The following is a description of a gene set: studied in species Homo sapiens Any process that starts or increases the frequency, rate or extent of sister chromatid segregation during mitosis. Human Gene Set: GOBP_POSITIVE_REGULATION_OF_MITOTIC_SISTER_CHROMATID_SEGREGATION, and this is the list of marker genes: MAD1L1, CDK1, NUMA1, MAD2L1BP, AURKB, KAT5 (NCBI Gene Id 10524), SKA3, PRAP1, SKA1